Given this list of marker genes APPL2, ADIPOQ, ADIPOR1, ACSL1, ADIPOR2, APPL1, CSNK2B, SLC27A1, here is a description of the gene set: studied in species Homo sapiens Human Gene Set: GOBP_ADIPONECTIN_ACTIVATED_SIGNALING_PATHWAY The series of molecular signals initiated by adiponectin binding to its receptor on the surface of a cell, and ending with the regulation of a downstream cellular process, e.g. transcription.